The following is a description of a gene set: species: Homo sapiens Human Gene Set: GOBP_PERK_MEDIATED_UNFOLDED_PROTEIN_RESPONSE The series of molecular signals mediated by the endoplasmic reticulum membrane stress sensor PERK (PKR-like ER kinase). Begins with activation of PERK in response to endoplasmic reticulum (ER) stress and ends with regulation of a downstream cellular process, e.g. transcription. The main substrate of PERK is the translation initiation factor eIF2alpha. Serine-phosphorylation of eIF2alpha by PERK inactivates eIF2alpha and inhibits general protein translation. In addition, eIF2alpha phosphorylation preferentially increases the translation of selective mRNAs such as ATF4 (activating transcription factor 4), which up regulates a subset of UPR genes required to restore folding capacity., and this is the list of marker genes: QRICH1, ATAD3A, NFE2L2, AKT2, PPP1R15B, EIF2S1, PPP1R15A, HSPA5, ATF4, AKT3, PTPN1 (NCBI Gene Id 5770), DDIT3, RPAP2, NCK2, ABCA7, TMED2, NCK1, AGR2, DDRGK1, AKT1, PTPN2, TMEM33, EIF2AK3, BOK